Given this list of marker genes Basp1, Nphs1, Foxc2, Foxj1, Nphs2, Cited1, Adipoq, Six2, Cd34, Prom1, Lamb2, Wt1, Stat1, Pax8, Wwtr1, Gpr4, Ednra, Cd24a, Mef2c, Smo, Pdgfb, Ctnnb1, Klf15, Acta2, Prkx, Ednrb, Notch1, Ptpro, Iqgap1, Cd2ap, Edn1, Jag1, Wnt9b, Notch2, Ampd2, Mmp9, Lhx1, Yap1, Gata3, Podxl, Sall1, Grem1, Gdnf, Lif, Mtss1, Asxl1, Osr1, Fat4, Magi2, Ext1, Pax2, Myo1e, here is a description of the gene set: The process in which relatively unspecialized cells acquire specialized structural and/or functional features of an epithelial cell that characterize the cells of the kidney as it progresses from its formation to the mature state. Mouse Gene Set: GOBP_EPITHELIAL_CELL_DIFFERENTIATION_INVOLVED_IN_KIDNEY_DEVELOPMENT studied in species Mus musculus